The following is a description of a gene set: species: Homo sapiens Human Gene Set: GOBP_POSITIVE_REGULATION_OF_DOPAMINE_RECEPTOR_SIGNALING_PATHWAY Any process that activates or increases the frequency, rate or extent of the dopamine receptor protein signaling pathway. A dopamine receptor signaling pathway is the series of molecular signals generated as a consequence of a dopamine receptor binding to one of its physiological ligands., and this is the list of marker genes: LRRK2, PRMT5, CAV2, VPS35, DRD3